Given this list of marker genes Nedd4l, Scn4b, Dmd, Camk2d, Neto1, Scn3b, Agrn, Osr1, Fgf13, Tmem168, Cav3, Ptpn3, Scn2b, Scn1b, Cnksr3, Stk39, Tesc, Wnk3, Fxyd1, Slmap, Nedd4, Rangrf, Nherf1, Grp, Slc9a1, Kcnq1, Tescl, Ank3, Drd4, Ywhah, Gpd1l, Plcb1, Wnk2, Atp1b1, Chp1, Fgf12, Pcsk9, Fxyd2, here is a description of the gene set: Mouse Gene Set: GOBP_REGULATION_OF_SODIUM_ION_TRANSMEMBRANE_TRANSPORTER_ACTIVITY Any process that modulates the frequency, rate or extent of sodium ion transmembrane transporter activity. studied in species Mus musculus